The following is a description of a gene set: Each fraction of mouse hematopoietic cells was purified by cell sorting from bone marrow of 8-week-old C57BL/6 mice, and its gene expression was analyzed. Genes down-regulated in comparison of B cells versus NKT cells. from publication Konuma T, Nakamura S, Miyagi S, Negishi M, Chiba T, Oguro H, Yuan J, Mochizuki-Kashio M, Ichikawa H, Miyoshi H, Vidal M, Iwama A (PMID 21540074) studied in species Homo sapiens Human Gene Set: GSE27786_BCELL_VS_NKTCELL_DN, and this is the list of marker genes: MZT2B, OSM, LOXL2, NOP2, P2RY6, ADCK1, PRRT1, CDON, TENM1, CUL9, DESI1, CCDC88B, GOLM1, KDM6A, ORAI1, GPR65, CCDC33, IGF2BP1, SCAF1, AKNA, KCTD15, MOBP (NCBI Gene Id 4336), MMD, LEPR, CHI3L1, SDF4, CSNK1G1, SNX33, RIT1, SARS1, TBC1D10C, GLRX, ACACB, FBLIM1, KCTD10 (potassium channel tetramerization domain containing 10), TRIM68, TASP1, USP25, GPAA1, CCDC115 (NCBI Gene Id 84317), SLC17A3, TECR, TTC39B, MAP7D1, MBOAT1, MMS19, WASHC3, PLSCR1, MBNL1, KBTBD2, MTFR1L, TMX4, TRIP12, ELAC1, SRBD1, SRSF12, FGD5, TMEM9B, YWHAH, NAT10, IGF2R, PAM, ZHX2, PYCARD, SEPTIN2, ARHGAP5, GLRA1, METTL27, ST3GAL6, PCCA, TBRG1, GABRG3, SRI, ROBO2, VIPR1, PDLIM1, RTN4RL1, NABP1, SLC25A1, ATP1B1, RETSAT, INTS5, TBCEL, ABCC5, TM6SF1, RCBTB1, CYP4A22, PABPC1, HSPB1, CPSF1, GRK5, PTPRE, ANTKMT, PTTG1IP, PEDS1, IFNA1, VPS28, SGPP2, KLF10, LDAF1, ACTL10, DCN, MAPK14, HK1, CD200R1, GADL1, BSCL2, WAPL, MED21, ABCA7, RTL8B, IKBKE, GAB3, RNF24, CRTC3, SEMA3A, FSD2, NCEH1, CRIM1, NKX2-3, COPG1, ANXA6, PGLYRP1, EVA1B, SMC4, SLC16A2, DNMBP, PRKDC, RAB2A, PIGX, CCDC138, FGF13, LUZP1, TMLHE, TMIE (NCBI Gene Id 259236), DCTN1, FOCAD, IFI27, JAK2, CCDC191, SMOX, MYO1H, ATP8B2, RGS1, ARL15, VPS26C, OSMR, NAA10, DYNC1I2, CNNM3 (NCBI Gene Id 54786), GMFG, ABCG4, FAM8A1, ANKH, TNFRSF11A, HACD3, LBP, NFIC, PPIP5K1 (diphosphoinositol pentakisphosphate kinase 1), JPT1, TENT5A, PANX1, TMEM176B, BDH1, COL10A1, ITPK1, NGLY1, CHD3, DPYSL4, VPS26B, ATP10A, TYRO3, ZDHHC18, PATZ1, EFHC2, P4HA3, AGTRAP, MRPS6, HM13, GMPPA, LOXL4, RPS10, CNDP2 (NCBI Gene Id 55748), KRT28, KRT81, SLK, ADCY5, MPPE1, EIF3B, SLC7A5, ARHGAP18, FLOT1, NDFIP2 (NCBI Gene Id 54602), OXCT2, ITM2B, GOSR1, PRKAR1A, SPRY2, SEC16B, COX8A (NCBI Gene Id 1351)